The following is a description of a gene set: studied in species Homo sapiens Human Gene Set: HP_MULTIPLE_PRENATAL_FRACTURES Multiple prenatal fractures The presence of bone fractures in the prenatal period that are diagnosed at birth or before., and this is the list of marker genes: NEB, COL1A2 (collagen type I alpha 2 chain), LBR, KLHL40, PPIB, COL1A1 (collagen type I alpha 1 chain), LMOD3, ACTA1, P3H1, KLHL41, MESD, CRTAP, TRIP4, MBTPS2, CCDC134, ASCC1, TAPT1, TPM3